Given this list of marker genes CHUK, IKBKG, IKBKB, here is a description of the gene set: species: Homo sapiens Reactome Pathway: IKBKB deficiency causes SCID Four patients with early-onset, life-threatening microbial infections and failure to thrive were found to carry a homozygous duplication c.1292dupG in exon 13 of IKBKB gene that results in a lack of expression of IKBKB (Pannicke U et al. 2013). IKBKB deficiency is associated with severe combined immunodeficiency (SCID), a health condition characterized by low levels of immunoglobulins (hypogammaglobulinemia). Further phenotype assessment revealed that patients peripheral-blood B cells and T cells had normal counts but were almost exclusively of naive phenotype. Regulatory T cells and gamma delta T cells were absent. part of: Diseases associated with the TLR signaling cascade